The following is a description of a gene set: from publication Goldrath AW, Luckey CJ, Park R, Benoist C, Mathis D (PMID 15548615) Mouse Gene Set: GOLDRATH_IMMUNE_MEMORY species: Mus musculus 'Memory genes' expressed uniquely in CD8+ memory T lymphocytes (compared with effector or naive cells) Naive T cells proliferate independently of cognate antigen when introduced into lymphopenic hosts. Lymphopenia-induced proliferation depends on low-affinity MHC/self-peptide complexes and on IL-7. To elucidate the intracellular signals mediating this proliferation, we analyzed changes in gene expression in naive CD8+ T cells at different times after their transfer into a lymphopenic environment. The genes induced in response to lymphopenia were largely an attenuated subset of those turned up by full antigenic stimulation, including genes related to cell cycling, whereas excluding genes specifically associated with effector activity. After the initial phase of proliferation in an empty compartment, the naive T cells adopted a stable pattern of gene expression similar to that of antigen-experienced memory cells. Thus, T cells proliferating in lymphopenic hosts do not exhibit a unique gene-expression profile, instead relying on traditional signals for this antigen-independent proliferation; this process ultimately results in differentiation to authentic memory cells., and this is the list of marker genes: Hcfc1r1 (NCBI Gene Id 353502), Pald1 (NCBI Gene Id 27355), Eomes, Ifnar2, Il15ra, Nr1d2, Ank, ENSMUSG00000139834, Prkcz, Chchd7, Prss12, Pros1, Tirap, Mcoln2, Rrm2b, Ctsw, Il10ra, Reck, Eci1 (enoyl-Coenzyme A delta isomerase 1), Usp48, Pde8a, Cd55, Abcb1a, ENSMUSG00000137801, Bmyc, Bag3, Nckap1, Rpgr, Sema4f, Golim4, Akr1c13, Aqp9, Sorbs1, Lpin1, Chpt1, Slc2a1, Ptpn22, Fcgrt, Gpc1, Prkce, Zmat3, Cd160, Il10rb, Rnase4, Kctd12, Ldaf1, Traf1, Mapk12, Cipc, Cyp4v3 (NCBI Gene Id 102294), F2r, Angptl4, Gk, Fhit, Vrk1, Sos2, Rras, Dock9, Vkorc1, Tmem141, Prnp (prion protein), Rnf138, Plcd1, Antxr2, Pcgf2, Pou6f1, Plekha5, Rasa4 (RAS p21 protein activator 4)